The following is a description of a gene set: studied in species Mus musculus electronically inferred by orthology from the curated human pathway part of: Sensory perception of taste Reactome Pathway: Sensory perception of salty taste This event has been computationally inferred from an event that has been demonstrated in another species.<p>The inference is based on the homology mapping from PANTHER. Briefly, reactions for which all involved PhysicalEntities (in input, output and catalyst) have a mapped orthologue/paralogue (for complexes at least 75% of components must have a mapping) are inferred to the other species., and this is the list of marker genes: Scnn1g, Scnn1a, Scnn1b (NCBI Gene Id 20277)